Given this list of marker genes NIT2, ATF4, ASRGL1, ASNS, ASNSD1, here is a description of the gene set: Human Gene Set: GOBP_ASPARAGINE_METABOLIC_PROCESS The chemical reactions and pathways involving asparagine, 2-amino-3-carbamoylpropanoic acid. studied in species Homo sapiens